Given this list of marker genes SPACA6, CORO1A, PCDH17, GPR37, CAMK1D, TRIM8, CDH2 (NCBI Gene Id 1000), GRB2, TTC13, INHA (inhibin subunit alpha), KCNK12 (NCBI Gene Id 56660), EPB41L4B, SORCS2, PELO, FGF9, ASB2, OTOS, SPI1, CCNYL1, RBL1, SORBS3, TMEM105, SCN5A, KIRREL2, CHD5, LMO3, PLEKHH3, PPP1R9B, DUSP9, FAM53C, RAB26, TREML2, AIG1, ABTB3, KCNIP2, TAFAZZIN, ZMAT3, WNT2B, ARHGAP8, NLK, KCNB1, EPHA2, MYO7A, MLIP, ANKRD2, PTK2B, CBFA2T3, GGN, HOXA7, ERG, PAK3, ITGA3, NUMBL, GNA11, DPYSL5, TGFB3, CHRD, SH3BP1, DEF6, NEXN-AS1, GJB1, DDIT4L, MTSS1, RBPJ, CTDNEP1, EFNA1, CORO2A, MLLT11, ELAVL3, LINC00683, DGKD, NETO2 (NCBI Gene Id 81831), EPB41, HSD3B7, GNB3, DNAJB5, DSCAM, GABRG2, NR4A3, PEX10, EPHB2, LZTS2, BCL11B, UBE2D3, CCND2, KLHL40, CHRDL1, TRIP10 (thyroid hormone receptor interactor 10), GSE1, CDYL2, EPHB6, CD47, HYCC1, ITGA6, RNF13, RUNX1, GCNT3, SEMA4B, SOST, MINK1, GNAS, EMILIN3, OTX1, PPP1R21, CALB1, AKAP12, CORO1C, CALM3, CKM, IL23A, KCNMA1, CAVIN2, FAM89B, MAZ, BRME1, BRSK2, TRPV3, VKORC1L1, PICK1, ONECUT1, CAMK2G, SLC26A9, KLHL13, ISL1, NDUFA4L2, KHDRBS2, GIT2, VEGFA, HRH3, SEC31B, PLEC, MAP1A, PODXL, NCOA5, PPP1R17, FLT3, DAAM1, CDK5, TTC17, ZNF532, GPR162, CFL1, SOX12, SHCBP1L, PLCB3 (NCBI Gene Id 5331), ELP5, C1QC, CACNA1H, MUSK (NCBI Gene Id 4593), HOXB7, MACF1, FLNC, IRF1 (NCBI Gene Id 96501), SCAI, KLF10, KCNJ4, CELF3, SORBS1, ELAVL4, DLL4, NEURL1, THRA, PRM2, RXRG, SCRT2, DTX2, VPS13A, CA7, FOXP1, HES6, RTL9, NSG2, CAMK2A, WNT10A, RORC, CYLD, KCNH2, SLC39A5, PDGFB, NAA40, GPM6B, RAB5B, CER1, CDC42SE1, SH3GLB2, ARL4A, WFIKKN2, NODAL, RELL2, ID1, ABLIM3, EMSY, SPTAN1, WNT6, POU2F3, TUBB2B (NCBI Gene Id 347733), PPP2R2B, ZNF644, MED10, ZNF706, ITGA1, TSHR, NBL1, FAM98A, KMT2E, CNNM2, ERF, WTAP, CYP26A1, EIF4ENIF1, LGALS1, PLK4, DUSP10, BCL9L, PARP8, RYR1, SLC4A2, CACNA2D2, CCNJL, FRMD5, DRP2, CHMP4B, CACNB3, GK, IDE, MAP3K3, AMD1, ARV1, AGO1, KCNQ1DN, PSIP1, EXOC6, SERBP1, NSD1, CITED2, RANGAP1, IRX5, HDAC3, SPOP, ARHGAP36, GOLM2 (golgi membrane protein 2), TSPAN33, IER5L, MPPED2, PPTC7, MYLIP, ARRB2, PLCB1, CCL27, WNT9A, LURAP1L, ERN1, GPD1L, STC2, MGAT1, here is a description of the gene set: Human Gene Set: E47_01 Genes having at least one occurrence of the motif VSNGCAGGTGKNCNN in the regions spanning 4 kb centered on their transcription starting sites. This matches the TCF3 transcription factor binding site V$E47_01 (v7.4 TRANSFAC). studied in species Homo sapiens